Given this list of marker genes NR4A2, NR4A3, CRHR1, NR4A1, CRHR2, here is a description of the gene set: Any process that results in a change in state or activity of a cell or an organism (in terms of movement, secretion, enzyme production, gene expression, etc.) as a result of a corticotropin-releasing hormone stimulus. Corticotropin-releasing hormone is a peptide hormone involved in the stress response. Human Gene Set: GOBP_RESPONSE_TO_CORTICOTROPIN_RELEASING_HORMONE species: Homo sapiens